The following is a description of a gene set: species: Homo sapiens Pathway Definition from KEGG: (S,N) -> (MBL2,COLEC10/11,FCN) Human Gene Set: KEGG_MEDICUS_PATHOGEN_SARS_COV_2_S_N_TO_LECTIN_PATHWAY_OF_COAGULATION_CASCADE SARS-CoV-2 S/N to lectin pathway of coagulation cascade. Pathway ID: N01316. Pathway type: Pathogen. Pathway class: nt06171 SARS coronavirus 2 (SARS-CoV-2)., and this is the list of marker genes: FCN2, FCN1, COLEC11, MBL2, COLEC10, FCN3